Given this list of marker genes ABHD17A, GBP2, LAMP2, BTK, MAPK8, TRIM31 (NCBI Gene Id 88008), MARCHF5, CARD8, PYDC5, TREM2, PLCG2, EIF2AK2, CD36, ZDHHC1, ABHD8, NLRC3, ZDHHC5 (zinc finger DHHC-type palmitoyltransferase 5), PTPN22, IFI16, IRGM, MYD88 (NCBI Gene Id 4615), PYDC2, BRCC3, HSPA8, MAVS, DHX33, TLR6, TRIM65, KCNK13, CPTP, KCNK6, TLR4, LATS2, ATAT1, OGT, TRIM11, NLRP2B, MEFV, SIRT2, CSNK1A1 (casein kinase 1 alpha 1), PPP2CA, DDX3X, NEK7, FBXL2, GBP5, STMP1 (NCBI Gene Id 649778), MARK4, PYDC1 (NCBI Gene Id 260434), USP50, ZDHHC12, P2RX7, PRKD1, LATS1, here is a description of the gene set: Human Gene Set: GOBP_REGULATION_OF_INFLAMMASOME_MEDIATED_SIGNALING_PATHWAY studied in species Homo sapiens Any process that modulates the frequency, rate or extent of an inflammasome-mediated signaling pathway.